Given this list of marker genes INSR, MET, CSF1R, FGF3, EFNA4, FLT3, VEGFC, FGF9, NTF4, FGF2, AREG, ANGPT2, EGFR, PIK3R2, EFNA3, IGF1R, FLT3LG (NCBI Gene Id 2323), FGFR4, INS, NRAS, VEGFA, FGF18 (fibroblast growth factor 18), VEGFD, BDNF, AKT2, FGF10, AKT1, EGF (epidermal growth factor), GRB2, EREG, HRAS, FGF16, KIT, ERBB2, KDR, FGF22, PDGFB, FGFR1, PIK3R3, NTRK2, ERBB3, FGF23, NGFR, SOS1 (NCBI Gene Id 7838), CSF1, FGF6, PIK3CB, FGF5, EFNA1 (NCBI Gene Id 1942), PDGFD, PIK3R1, ANGPT1, FGF7, PIK3CA, EFNA5, FGF20, AKT3, PDGFRB, FGF4, FGF21, KRAS, FGFR3, FGF19, NTRK1, EPHA2, FGF17, IGF1, TEK, ERBB4, EFNA2, KITLG, FGFR2, FLT4, NTF3, SOS2, IGF2, PDGFRA, HGF, FLT1, ANGPT4, PDGFC, PGF, NGF, FGF8, PIK3CD, TGFA, VEGFB, FGF1, PDGFA, here is a description of the gene set: Human Gene Set: KEGG_MEDICUS_REFERENCE_GF_RTK_RAS_PI3K_SIGNALING_PATHWAY studied in species Homo sapiens Pathway Definition from KEGG: GF -> RTK -> GRB2 -> SOS -> RAS -> PI3K -> PIP3 -> AKT GF-RTK-RAS-PI3K signaling pathway. Pathway ID: N01658. Pathway type: Reference. Pathway class: nt06530 PI3K signaling.